Given this list of marker genes TADA1, MSL1, TADA2B, BRD8 (bromodomain containing 8), TRRAP, H2AC12, ING3, VPS72, KANSL2, CLOCK, ELP1, CREBBP, H2AC6, TADA3 (transcriptional adaptor 3), MORF4L2, MCRS1, ACTB, H2BC9, H2AC25, H2BC17 (NCBI Gene Id 8348), TAF5L, KAT8, ELP3, H3C1, H2BC14, SAP130, TAF10, RUVBL1, H2AC1, RBBP7 (RB binding protein 7, chromatin remodeling factor), JADE1, TAF12, SUPT7L, H2BC18, H2BC11, OGT, NCOA1, PHF20, KAT14, H2BC13 (NCBI Gene Id 8340, H2B clustered histone 13), ATXN7L3, H2BC26, KAT2B, BRD1, ELP4 (NCBI Gene Id 54515), MSL3, WDR5, ATF2, BRPF3, KAT5, H2BC1, ING4, BRPF1, H2BC12, HCFC1, YEATS2, MSL2, KAT6B, ELP5, HAT1, MEAF6, TAF6L, H2AC7, EPC1, MORF4L1, KAT2A, SUPT20H, RUVBL2, H4C1, MBIP (NCBI Gene Id 51562), H2BC15, ZZZ3, DMAP1, KAT6A, KANSL1, H2AC11, TADA2A, USP22, ACTL6A, JADE2, KAT7, SUPT3H, H2BC3, YEATS4, H3C15, ELP6, ING5, H2AC21, H2BC5, NCOA2, EP300, EP400, ELP2, MRGBP, H2BC21, ENY2, SGF29, H2AC18, PAX3, H2AC4, KANSL3, H2AC20, ATXN7, H2BC4, JADE3, H2AC14, TAF9, DR1, here is a description of the gene set: Histone acetyltransferases (HATs) involved in histone modifications are referred to as A-type or nuclear HATs. They can be grouped into at least four families based on sequence conservation within the HAT domain: Gcn5/PCAF, MYST, p300/CBP and Rtt109. The p300/CBP and Rtt109 families are specific to metazoans and fungi respectively (Marmorstein & Trievel 2009). Gcn5/PCAF and MYST family members have no significant sequence homology but share a globular alpha/beta fold with a common structure involved in acetyl-Coenzyme A (ACA) binding. Both use a conserved glutamate residue for the acetyl transfer reaction but may not share a common catalytic mechanism. The p300/CBP HAT domain has no homology with the other families but some structural conservation within theACA-binding core. In addition to histone acetylation, members of all 3 human HAT families have been shown to acetylate non-histones. <br><br>HATs and histone deacetylase (HDAC) enzymes generally act not alone but as part of multiprotein complexes. There are numerous examples in which subunits of HAT or HDAC complexes influence their substrate specificity and lysine preference, which in turn, affect the broader functions of these enzymes (Shahbazian & Grunstein 2007).<br><br> N.B. Histone literature typically refers to coordinates of the protein after the initiating methionine has been removed. part of: Chromatin modifying enzymes Reactome Pathway: HATs acetylate histones studied in species Homo sapiens